The following is a description of a gene set: Human Gene Set: GOBP_DNA_TOPOLOGICAL_CHANGE The process in which a transformation is induced in the topological structure of a double-stranded DNA helix, resulting in a change in linking number. species: Homo sapiens, and this is the list of marker genes: TOP2B, TOP3A, TOP1MT, ERCC3, TOP3B, TOP2A, TOP1, HMGB2, TDRD3, HMGB1